The following is a description of a gene set: studied in species Mus musculus Mouse Gene Set: GOMF_PHOSPHATIDYLINOSITOL_3_5_BISPHOSPHATE_3_PHOSPHATASE_ACTIVITY Catalysis of the reaction: 1-phosphatidyl-1D-myo-inositol 3,5-bisphosphate + H2O = 1-phosphatidyl-1D-myo-inositol 5-phosphate + phosphate + 2 H+., and this is the list of marker genes: Mtm1, Ptprq, Mtmr1, Mtmr6, Mtmr4, Mtmr3, Mtmr2, Mtmr14